The following is a description of a gene set: from publication Yang F, Foekens JA, Yu J, Sieuwerts AM, Timmermans M, Klijn JG, Atkins D, Wang Y, Jiang Y (PMID 16261164) Genes down-regulated in laser microdissected (LCM) samples of early primary breast tumors expressing ESR1 vs the ESR1 negative ones. species: Homo sapiens Human Gene Set: YANG_BREAST_CANCER_ESR1_LASER_DN About 70-80% of breast cancers express estrogen receptor alpha (ER-alpha), and estrogens play important roles in the development and growth of hormone-dependent tumors. Together with lymph node metastasis, tumor size, and histological grade, ER status is considered as one of the prognostic factors in breast cancer, and an indicator for hormonal treatment. To investigate genes and pathways that are associated with ER status and epithelial cells in breast tumor, we applied laser capture microdissection (LCM) technology to capture epithelial tumor cells from 28 lymph node-negative breast tumor samples, in which 17 patients had ER-alpha+ tumors, and 11 patients have ER-alpha- tumors. Gene expression profiles were analysed on Affymetrix Hu133A GeneChip. Meanwhile, gene profiles using total RNA isolated from bulk tumors of the same 28 patients were also generated. In total, genes and genes with significant P-value and having significant differential expression between ER-alpha+ and ER-alpha- tumors were identified from the LCM data set and bulk tissue data set, respectively. A total of genes were found to be common in both data sets, while genes were unique to the LCM data set and genes were present only in the bulk tumor data set. Pathway analysis with the genes using Gene Ontology suggested that genes involved in endocytosis, ceramide generation, Ras/ERK/Ark cascade, and JAT-STAT pathways may play roles related to ER. The gene profiling with LCM-captured tumor cells provides a unique approach to study epithelial tumor cells and to gain an insight into signaling pathways associated with ER., and this is the list of marker genes: MCCC1, PLS3, PPP1CB, ACOT9, GSTP1, FOXC1, FXR1, SMCO4, ODC1, SGCE, FSCN1, ANP32E, ANXA1, SEC63, UBE2J1, CYP39A1, IFRD1, INAVA, PRNP, RRP1B (NCBI Gene Id 23076), ACAT2, PRKD3, BBOX1, SEL1L3, SERBP1, HDAC2, BMAL2, ARHGEF4, CXCR4, UGT8, ST3GAL6, CHI3L1, AK2, PALS2, HSPA14, PLD1, SNX3, KIF14, SYNCRIP, BICD1, IFNAR2, TTLL4, RSU1, FNDC3B, DSC2, TCF7L2, SOS1